Given this list of marker genes ST3GAL2, ST8SIA2, NEU1, B4GALT6 (beta-1,4-galactosyltransferase 6), NEU3, GM2A, C20orf173, ST3GAL1, B4GALNT1, ST6GALNAC4 (ST6 N-acetylgalactosaminide alpha-2,6-sialyltransferase 4), ABCA2, ST6GALNAC3, NEU4, ST3GAL3, HEXB, NAGLU, B3GALT4, ST8SIA4, NEU2, CLN6, ST8SIA3, ST3GAL5, ST6GALNAC6, HEXA, GLB1, B4GALT5, ITGB8, ST8SIA6, ST6GALNAC5, here is a description of the gene set: Human Gene Set: GOBP_GANGLIOSIDE_METABOLIC_PROCESS The chemical reactions and pathways involving ceramide oligosaccharides carrying in addition to other sugar residues, one or more sialic acid residues. studied in species Homo sapiens